The following is a description of a gene set: Human Gene Set: HP_INCREASED_RED_BLOOD_CELL_MASS studied in species Homo sapiens Increased red blood cell mass The presence of an increased mass of red blood cells in the circulation., and this is the list of marker genes: JAK2, VHL, EGLN1, SH2B3, EPOR